The following is a description of a gene set: electronically inferred by orthology from the curated human pathway This event has been computationally inferred from an event that has been demonstrated in another species.<p>The inference is based on the homology mapping from PANTHER. Briefly, reactions for which all involved PhysicalEntities (in input, output and catalyst) have a mapped orthologue/paralogue (for complexes at least 75% of components must have a mapping) are inferred to the other species. part of: Metabolism of polyamines Reactome Pathway: Agmatine biosynthesis species: Mus musculus, and this is the list of marker genes: Agmat, Azin2